The following is a description of a gene set: Any process that modulates the frequency, rate or extent of protein localization to chromatin. studied in species Homo sapiens Human Gene Set: GOBP_REGULATION_OF_PROTEIN_LOCALIZATION_TO_CHROMATIN, and this is the list of marker genes: PIAS4, VCP, VCPIP1, VRK1, SPI1, SETD2, LNCPRESS1, SIRT6, CDK9, RNF4